The following is a description of a gene set: studied in species Homo sapiens Human Gene Set: GOBP_POSITIVE_REGULATION_OF_RRNA_PROCESSING Any process that activates or increases the frequency, rate or extent of rRNA processing., and this is the list of marker genes: HEATR1, DIMT1, UTP15, RIOK1, TRMT112 (NCBI Gene Id 51504), SIRT7, RIOK2, BUD23, WDR43, WDR75